The following is a description of a gene set: APC/C-mediated degradation of cell cycle proteins Mouse Gene Set: REACTOME_APC_C_MEDIATED_DEGRADATION_OF_CELL_CYCLE_PROTEINS studied in species Mus musculus, and this is the list of marker genes: Cdk1, Psmc6, Psma5, Cdc27, Plk1, Psma6, Ube2s, Skp2, Psmc5, Psmb3 (proteasome (prosome, macropain) subunit, beta type 3), Ube2e1, Ccna1, Anapc1, Aurka, Bub3, Anapc15, Ccnb1, Psma2, Psmc1, Psmd12, Psmd1, Fbxo5, Uba52, Psmd6, Psmd8, Anapc7, Psmb4, Psmd13, Ube2c, Psmb5, Psmd11, Psmd7 (NCBI Gene Id 17463), Skp1, Ubb, Pttg1, Psma4, Cdc26, Psmd3, Cdc16, Psma3, Fzr1, Rb1, Nek2, Psmb6, Bub1b, Cdc14a, Psmd14, Aurkb (NCBI Gene Id 20877), Ube2d1, Mad2l1, Psmc4, Psma1, Psmb7, Anapc5, Cdc20, Adrm1, Ccna2, Psmc3 (NCBI Gene Id 19182), Psmc2, Anapc4, Anapc11, Cul1, Cdc23, Psmb2, Anapc10 (anaphase promoting complex subunit 10), Anapc16, Anapc2, Cdk2, Ubc, Uba52rt, Psma7, Psmd2, Psmb1, Rps27a